Given this list of marker genes PSMB9, LMOD2, ABCC6, ATRX, RPL3L, SDHA, MYL2, NAA10, here is a description of the gene set: Human Gene Set: HP_CARDIOGENIC_SHOCK species: Homo sapiens Cardiogenic shock Severely decreased cardiac output with evidence of inadequate end-organ perfusion (i.e., tissue hypoxia) in the presence of adequate intravascular volume.